Given this list of marker genes TXN, CCND2, NHP2, SNRPE, RANBP1, SMS (NCBI Gene Id 6735), PAICS, PHB1, EBNA1BP2, TNFRSF4, PGAM1, C1QBP, HSPD1, DNPH1, TOMM40 (translocase of outer mitochondrial membrane 40), CCT5, DCTPP1, PKM, NDUFAB1, NOLC1, MRPL14, SNRPD1, MRPL12 (NCBI Gene Id 6182), CCT2, EEF1E1, TIMM13, TNFRSF18, NDUFB3, TNFRSF9, LSM5, IL2RA, PRMT1, EIF5B (eukaryotic translation initiation factor 5B), TXNDC17, PPA1, PDCD5, SSBP1, DDX21 (NCBI Gene Id 9188), CCT3, TUBB, NME1 (NME/NM23 nucleoside diphosphate kinase 1), IL1R2, EIF5A, PRDX1, FABP5, LSM2, ATP5MC1, PCNA, DUT, SRM, here is a description of the gene set: Human Gene Set: GAVISH_3CA_METAPROGRAM_CD4_T_CELLS_GLYCOLYSIS_MYC In this study, an extensive analysis was conducted to define meta-programs (MPs) capturing intra-tumor heterogeneity across a spectrum of tumor types. The approach utilized non-negative matrix factorization (NMF) to analyze each cell type separately within individual tumor samples. This involved the analysis of malignant cells, macrophages, fibroblasts, endothelial cells, epithelial cells, T-cells, and B-cells. NMF was executed with varying parameter values (K=4, 5, 6, 7, 8, 9), thereby generating 39 programs for each cell type per sample. Each NMF program was summarized by the top genes based on NMF coefficients.\nRobust MPs were then delineated for each cell type using a set of stringent criteria, including recurrence within the same tumor, similarity to programs in other tumors, and non-redundancy within a tumor. Subsequently, these robust NMF programs were clustered (per cell type) based on Jaccard similarity, leading to the identification of MPs associated with each cell type.\nTo enhance the quality of the MPs, a refinement steps were undertaken, involving the removal of MPs suspected of reflecting low-quality data (with an overrepresentation of ribosomal proteins or mitochondrial-encoded genes), single-study inclusion, or similarity to miss-annotated cell types. Genes upregulated in subsets of cells of a given type within various tumors from publication Gavish A, Tyler M, Greenwald AC, Hoefflin R, Simkin D, Tschernichovsky R, Galili Darnell N, Somech E, Barbolin C, Antman T, Kovarsky D, Barrett T, Gonzalez Castro LN, Halder D, Chanoch-Myers R, Laffy J, Mints M, Wider A, Tal R, Spitzer A, Hara T, Raitses-Gurevich M, Stossel C, Golan T, Tirosh A, Suvà ML, Puram SV, Tirosh I (PMID 37258682) species: Homo sapiens